The following is a description of a gene set: Any process that activates or increases the frequency, rate or extent of T-helper 17 cell differentiation. Human Gene Set: GOBP_POSITIVE_REGULATION_OF_T_HELPER_17_CELL_DIFFERENTIATION species: Homo sapiens, and this is the list of marker genes: IL12RB1, IL23R, IL12B, OPA1, NFKBIZ (NFKB inhibitor zeta), BRD4, EP300, MIR21, MALT1, NFKBID, IL23A, BRD2